The following is a description of a gene set: The gene expression program underlying the specification of human cell types is of fundamental interest. The study authors generated human cell atlases of gene expression and chromatin accessibility in fetal tissues. For gene expression, the study authors applied three-level combinatorial indexing to >110 samples representing 15 organs, ultimately profiling ~4 million single cells. The study authors leveraged the literature and other atlases to identify and annotate hundreds of cell types and subtypes, both within and across tissues. Our analyses focused on organ-specific specializations of broadly distributed cell types (such as blood, endothelial, and epithelial), sites of fetal erythropoiesis (which notably included the adrenal gland), and integration with mouse developmental atlases (such as conserved specification of blood cells). These data represent a rich resource for the exploration of in vivo human gene expression in diverse tissues and cell types. species: Homo sapiens from publication Cao J, O'Day DR, Pliner HA, Kingsley PD, Deng M, Daza RM, Zager MA, Aldinger KA, Blecher-Gonen R, Zhang F, Spielmann M, Palis J, Doherty D, Steemers FJ, Glass IA, Trapnell C, Shendure J (PMID 33184181) Marker genes curated from the annotated cluster as represented in the Descartes Human Gene Expression During Development database. Human Gene Set: DESCARTES_MAIN_FETAL_THYMIC_EPITHELIAL_CELLS, and this is the list of marker genes: PRSS16, GSTCD-AS1, SNORD11, TRMT12, ADAMTS17, KCNIP3, OXCT1, NPIPB2, GLRA4, ABCA3, ENSG00000235726, VPS26BP1, BMP8A, FAAH2, MRTFB, COL27A1, PASK, ZCWPW1, KYAT1, INTS12, ATL2, ETNK1, RNU6-137P, CLEC2L, PIK3IP1-DT, RBAK-RBAKDN, ALOX12P2, GLI2, CTSV, RPS7P10 (NCBI Gene Id 387907), LINC01273, TMEM221, ARMC6, PDCL3P5, MTND1P14, ZNF614, EXOC3L4, DDX50P1, RNY4P7, USP32P1, NFKB1, CLEC1A, C5orf34-AS1 (NCBI Gene Id 105374750), ZNF418, NSMAF, FAM118B, COX6B2, C22orf31, RNU6-705P, PGBD2, APBB2, FBXO36-IT1, GUCA1B, EARS2, KIAA0895LP1, LINC02955, PKP4-AS1, CUL9, ARMC10, PEX1, DCDC2C, GPLD1, LINC02388, MBTPS1-DT, NTRAS, MST1R (NCBI Gene Id 5755), GTF2IRD2B, TMEM131, NXN, LINC01605, MIR205HG, PLXDC1, TP53AIP1, PIKFYVE, NQO1-DT, RPL23AP53, LINC00313, NSRP1P1, DNASE1L2, GJB6, RBM15-AS1, GUCY2F, BCAS4, RTCB, SLC46A1, LINC02235, RIC1, NEURL4, RN7SL589P, DSG1-AS1, SETP12, ENSG00000227496, PTPRT, EEF1DP2 (NCBI Gene Id 650173), LINC01271, ENSG00000269729, PNCK, TYW3, PDC-AS1, CYP1B1-AS1, BCL10-AS1 (NCBI Gene Id 647393), FAM66A, NPM1P6, RASSF10-DT, PDE9A-AS1, TOMM22-DT, ARLNC1 (androgen receptor regulated long noncoding RNA 1), HLA-DRB9, RBMS3-AS3, CDH3, ATP10B, ZBTB47-AS1, SMIM14-DT, RAB42, LINC01600, MTFR2P1, KLF3-AS1, SFTPA2, EYA2, ENSG00000238372, UTP15, NPFFR2, UBXN7-AS1, NALT1, ANO9, LINC01337 (long intergenic non-protein coding RNA 1337), LGR4-AS1, TUSC8, ZFPM1-AS1, LINC01250, RTBDN, MFSD13B, DDB2, SYNE1, TBATA, LINC02436, DPP3-DT, RIGI, UST, GGA2, LINC02213, NEURL2, DEFA3, LINC00173, RPA4, MTCL1, POTEKP, ZBED2, FAM163A, GPHN, SMIM15-AS1, LINC02541, C4orf50, SPAG16-DT, POLR1HASP, PLTP, BICRA, MOV10, LINC02356, LY75 (lymphocyte antigen 75), NUBP2, OTULIN-DT, FRMD1, TBC1D2B, SLC22A23, IRS4, PAX1, NUBPL, PXT1, RNU6-196P, SIGLEC10-AS1, SNORD3B-1, LINC00559, QTRT2, LINC02427, EEF1A1P3, C12orf56, RDM1P5, IL31RA, M1AP, CCDC171, ICAM5, RMDN2-AS1, NARF-IT1, RPS3AP29, MRPS31P4, RMI2, LHFPL1, ENSG00000253363, BANF2, ABRAXAS2, SNX19, CYP3A4, RPSAP6, SAG, SUV39H2, GTF2IP4, NEURL3, RNU6-323P, PLEK2, ENSG00000259723, ANKRD22, PSMB11, FBXW10, FRS3 (NCBI Gene Id 10817), SLFN12, MTG1, UBA7, PLGRKT, IGFL2, PARP3, C8G, RPS26P18, APTX, DNAJA2-DT, LINC01780, SLC47A1P2 (SLC47A1 pseudogene 2), TRAPPC12, TMEM108-AS1, SCAND3, ENSG00000248994, LIPJ, ENSG00000265055, SYCP1, DIPK1A, RNU7-115P, GLB1L3, RPS23P6 (NCBI Gene Id 100271367), CUX1, THAP8 (NCBI Gene Id 199745), MAJIN, LINC01644, ENSG00000248973, CACNA1I, SLC9A3-AS1, ENSG00000228793, FLVCR1, MRPS9-AS2, SLIT3, SLC46A2, FTLP14, FOXN1, COL19A1, ZNF649-AS1, GHRH, RNU6ATAC27P, MCF2L, SPDYE12, PRKAR1B-AS1, NPM1P37, NEPRO-AS1, CNTNAP3, DNAJC3-DT, ENSG00000257989 (NCBI Gene Id 112268096), SMG6, LINC01500, TAFAZZIN, LINC02016, TCEA1P4, KIAA1549, C1RL-AS1, FAS, VWA2, NTF4, LINC01482, RGPD3, STARD9, GARIN2, SH3RF3, GRK7, KREMEN2, HSPE1P25, CARINH, ENPP7P10, DRP2, RPS3AP34, RNU6-107P, CLTCL1, MUC12-AS1, MGMT, TYK2, TDRD12, LINC01980, D2HGDH, C3orf22